Given this list of marker genes ZBTB4, PCYT2, SRSF2, SMC3, HS6ST3, H2AC12, ATAD5, STK35, CTDSPL2, CCNT1, GPAT2, PHC1, WEE1, TRMT2A (tRNA methyltransferase 2 homolog A), ATAD2, RRM2, EZH2, FIZ1, TMPO, CAND1 (NCBI Gene Id 55832), PRKDC, NUFIP2, TBX6, CNOT9, HNRNPUL1, PRPS1, ABI2, USP37, PCLAF, POLE4, NSD3 (nuclear receptor binding SET domain protein 3), IER5L, ZNF367, POLD3, CDCA7, GAPDH, EPHB1, MYH10, SLC9A5, CHD2, DNAJC5G, GON7, MCM4, RAB11B, TMEM143, PBRM1, SRSF1, UBR7, TAOK2, PCNA, PCSK1, SASS6, RAVER1, UXT, MCM3, RHCE, USP49, RHD, ILF3, EMSY, SEMA5A, ACBD6, BRME1, GPRC5B, PAX6, SPTB (spectrin beta, erythrocytic), APPL1, MAZ, CORT, RAD51, NASP, FHOD1, JADE1, SLC38A1, MCM7, DCK, H2BC12, SYNGR4, GINS3, SMC1A, ABRAXAS2, SIK2, ZCCHC8, MCM2, E2F8, ALDH6A1, TMEM108, VCAN, PKMYT1, STAG1, JPH1, ERBIN, ILF3-DT, PHF5A, TRMT6, GRIA4, HNRNPR, DCTPP1, SP3, CASP8AP2, NIPBL, NUP62, POLA1, POLR1G, UFD1, AK2, ING3, STMN1, CLSPN, INTS7, UGGT1, IL4I1, ZNF362, CTCF, THAP8, POLA2, EPC1, ACO2, WNT3, CBX5, CRK, PPP1R8, PHF13, NCL, RASAL2, RMI2, JADE2, TRMT13, FBXO5, KBTBD7, STAG2, MEIS2, CDC45, ZNF524, FMO4, EHBP1, E2F1, DNMT1, WDR62, DNAJC9, KCND2, MSH2, PRRC2C, SLCO3A1, ZNF565, YBX2, HMGXB4, HCN3, UNG, MCM6, POLE2, PODN, TREX2, ZNF687, ASXL2, MCM8, NECTIN1, NUP153, PPP1CC, ZNF644, ID3, LUC7L3, INSM1 (NCBI Gene Id 8196), PAQR4, EMC3, TOPBP1, AP4M1, TMEM187, SLC6A4, KIAA0825, CDC6, BRMS1L, ATF5, IPO7, E2F7, HIRA, NOLC1, KCNA6, SOAT1, ARHGAP6, SMAD6, GSPT1, GABRB3 (NCBI Gene Id 2562), HMGN2, PAN2, ZMYM2, E2F3, APH1A, SPINK5, TRA2B, HOXC10, RIBC1, MCMBP, STT3B, MTF2, SRSF7, SMC6, RPS6KA5, SNRPD1, DNAJC11, ADAMTS2 (NCBI Gene Id 9509), NABP2, TYRO3, KPNB1, ARHGAP11A, GEN1, CDK1, FANCD2, NRP2, PIM1, GMNN, H2AZ1, PPM1D, NELL2, DDX17, HNRNPA1, SUMO1, TFAP4, CDT1, EFNA5, KBTBD6, CDC25A, RBL1, CTNND2, RANBP1, HNRNPD, MXD3, OTUD7B, SREK1, DMD, EED, YTHDC1, NFATC2IP, DDB2, MRPL40, POLD1, POLR2A, ARID4A, here is a description of the gene set: species: Homo sapiens Genes having at least one occurrence of the motif TTTSGCGS in the regions spanning 4 kb centered on their transcription starting sites. This matches the transcription factor binding site V$E2F_Q4 (v7.4 TRANSFAC). Human Gene Set: E2F_Q4